Given this list of marker genes Rela, Uba52, Dhx9, Ubc (NCBI Gene Id 77003), Aim2, Dtx4, Chuk, Trim21, Ep300, Dhx36, Ddx41, Trim56, Nkiras1, Nkiras2, Nlrp4c, Nfkb2, Uba52rt, Tbk1, Ikbkb, Mre11a, Ikbkg, Nfkbia, Ctnnb1, Trim32, Sting1, Nfkbib, Stat6, Myd88, Rps27a, Ubb, Nfkb1, Irf3, Irf7, here is a description of the gene set: Cytosolic sensors of pathogen-associated DNA Mouse Gene Set: REACTOME_CYTOSOLIC_SENSORS_OF_PATHOGEN_ASSOCIATED_DNA studied in species Mus musculus